Given this list of marker genes Cldn5, Rock2, Notch4, Add1 (NCBI Gene Id 11518), Bmp4, Cdh5, Bmp6, Cul7, Atoh8, Vhl, Tgfbr1, Xdh, Ctnnb1, Acvrl1, Etv2, F11r, Vezf1, Foxj2, Il1b, Gdf2, Akap11, Tnf, Bmpr1a, Vcl, Vegfa, Dicer1, Notch1 (NCBI Gene Id 68125), Id1, Tmem100, Dsg2, S1pr2, Zeb1, Plcb1, Zdhhc21, Tnfrsf1a, Apold1, Ceacam1, Proc, Btg1, Ikbkb, Rock1, Jag1, S1pr3, here is a description of the gene set: Any process that modulates the frequency, rate or extent of endothelial cell differentiation. Mouse Gene Set: GOBP_REGULATION_OF_ENDOTHELIAL_CELL_DIFFERENTIATION species: Mus musculus